The following is a description of a gene set: species: Homo sapiens Mutation-activated KRAS/NRAS to ERK signaling pathway. Pathway ID: N00012. Pathway type: Variant. Pathway class: nt06260 Colorectal cancer. Human Gene Set: KEGG_MEDICUS_VARIANT_MUTATION_ACTIVATED_KRAS_NRAS_TO_ERK_SIGNALING_PATHWAY Pathway Definition from KEGG: (KRAS*,NRAS*) -> RAF -> MEK -> ERK -> CCND1, and this is the list of marker genes: MAP2K2, NRAS, BRAF, CCND1, MAP2K1 (mitogen-activated protein kinase kinase 1), MAPK1, MAPK3, RAF1, ARAF, KRAS